The following is a description of a gene set: from publication Zeng Z, Gu SS, Wong CJ, Yang L, Ouardaoui N, Li D, Zhang W, Brown M, Liu XS (PMID 36240281) Most patients with cancer are refractory to immune checkpoint blockade (ICB) therapy, and proper patient stratification remains an open question. Primary patient data suffer from high heterogeneity, low accessibility, and lack of proper controls. In contrast, syngeneic mouse tumor models enable controlled experiments with ICB treatments. Using transcriptomic and experimental variables from >700 ICB-treated/control syngeneic mouse tumors, developed a machine learning framework to model tumor immunity and identify factors influencing ICB response. Projected on human immunotherapy trial data, found that the model can predict clinical ICB response. further applied the model to predicting ICB-responsive/resistant cancer types in The Cancer Genome Atlas, which agreed well with existing clinical reports. Mouse Gene Set: ZENG_GU_ICB_CONTROL_METAGENE_31_PRECICTIVE_ICB_RESISTANCE Metagene_31 is enriched in LIHC, which has a low response rate to ICB treatment (Fig. 4D). Metagene_31 is also highly enriched in the syngeneic mouse models that are resistant to ICB treatment (Fig. 2C). The top genes in metagene_31 include Col2a1, Col9a1/2, and Sox8 (Fig. 5F and table S5), and enriched pathways include extracellular matrix (ECM) receptor interactions and collagens (Fig. 5, G and H). Sox8 is a transcription factor involved in embryogenesis and is highly expressed in most hepatocellular carcinomas, where it has been shown to promote tumor cell proliferation (41). Tumor Immune Dysfunction and Exclusion (TIDE) (8) analysis suggested that Sox8 is highly expressed in alternatively activated M2 tumor-associated macrophages (TAMs), which restrict intratumoral CTL infiltration. Col2a1 encodes the alpha-1 chain of type II collagen, a component of the ECM. Collagen induction has also been reported to confer immune evasion by physically impeding CTL infiltration (42). Moreover, metagene_31 level was positively correlated with the gene signature of alternatively activated M2 TAMs (Fig. 5I), which suppress CTL response (43). species: Mus musculus, and this is the list of marker genes: Bricd5, Trpm3, Chadl, Plch2, Fam210b, Arglu1, Arhgef26, Nhlrc1, Fzd3, Art4, Gng7, Camsap3, Cadps2, Dact2, Hs3st3b1, Ccdc106, Bcl11a, Gpr137c, Col9a3, Zscan10, Zfp853, Tyro3, Fzd9, Col2a1, Large2, Npw, Bcl7a, Wif1, Fam13a, Cdkn1c (NCBI Gene Id 12577), Tmem266, Wipf3, Cytl1, Shisa2 (NCBI Gene Id 320778), Fut9, Caprin2, Zfp704, Ccdc138, Bex1, Rhpn1, Sox13, Kcnmb1, Edar, Irx4, C1qtnf4, Acy1, Etv5, Kbtbd13, Faim2, Trim62, Emid1, Cd164l2, Ccdc187, Fam178b, Otx1, Myb, Lgr6, Adamts18, Tube1, Atp6v1b1, Id4, Slc29a4, Ism2, Slc38a3, Patz1, Dlk2, Nol4l, Adgrb1, Dpysl5, Catsperz, Peli3, Chrm1, Plekhb1, Dgki, Wnt6, Egflam, Spdef, Ttpa, Zfp879, Lama1, Klhdc7a, Dpysl4, Kcnip3, Adamts17, Ceacam10, Snph, Hunk, Pcsk6, Hdac2, Amd1, Trpv6, Rtl6, Lpar3, Kank4, Armh1, Dnmt3b, Ptchd4, Mia (MIA SH3 domain containing), Pld6, Hbs1l, Wnt5b (NCBI Gene Id 22419), Hs3st3a1 (heparan sulfate (glucosamine) 3-O-sulfotransferase 3A1), Amd2 (NCBI Gene Id 11703), Srsf12, Caskin1, Fam181b, Ntf3, Tnfrsf19, Nhsl1, Cep126, Hpse2, Papln, Tert, Plcxd1, Ccdc148, Frem2, Drd4, Sema6a, Tfap2c (transcription factor AP-2, gamma), Nxf7, Pou2af1, Sntb1, Trmt9b, Edaradd, St8sia6, Bex2, Ppp1r26, Sox8, Trappc5, Col9a1, Camkv, Timm44, Krt23 (NCBI Gene Id 94179), Sez6l, Tcaf2, Usp29, Shisa8, Pou2af3, Ccdc158, Zscan18, Klhl29, Rims3, Cdc40, Nme5, Cspg5, Stk26, Ildr1, Nrtn, Bhlha15, Cnn1, Kcnmb4, Map3k21, Rps6kl1, Jakmip2, Wfdc18, Gpr179, Vwa2, Cited4, Zfp711, Amt, Zfp937, Ncoa7, Col9a2, Bcas1, Cacng4, Elf5, Ppp1r36, Alox12, Cdk19, Gne, Msi1, Ctnnd2, Oxtr, Nrg2, Six2, Piwil2, Fbxo16, Tsen15, Rassf10, Amhr2, Cnih2, Tmem132b, Adgrb2, Ccnjl, Krr1, Ctbp2, Clxn, Adamts20, Lbhd2, Derl3, Pabpc4l, Thrsp, Fam131c, Zfp612, Tmem59l, Kctd14 (NCBI Gene Id 52424), Pnma8b, Slc22a17, Nos1ap, Tmem88b